Given this list of marker genes GGTLC3, GGT1, GGT3P, DPEP2, GGTA1, GGT7, GGTLC2, DPEP1, GGT2P, GGT6, GGT5, GGTLC1, here is a description of the gene set: The chemical reactions and pathways involving leukotriene D4. Human Gene Set: GOBP_LEUKOTRIENE_D4_METABOLIC_PROCESS studied in species Homo sapiens